Given this list of marker genes CBX7, GSTM5, BUB1B, CKS2, ARL4A, FIBIN, STOML2, NELFB, CACNA2D1, NEK2, TGIF1, SIX4, LBR, PHYH, APOE, ENAH, ALDOA, MIF, DSG2, PTCH1, CACNA1A, CDH3, SNRPA1, ADAM23, PSRC1, DPPA3, FKBP3, FZD5, CPSF4L, SYCP3, SOX2, TUBB4B, TCF7, NADK2, SLC25A40, IFITM3, PMM1, CLDN7, ITM2A, PIM1, KIF20A, SULF2, SLC20A1, CERS4, HNRNPA1L2 (NCBI Gene Id 653821), ASH2L, H2BC4, BCLAF3, G3BP1, PIPOX, IPO5, TUBB2B, MTF2, GRB10, MT1F, CKB, PHB1, DNMT1, CWF19L2, HSP90AA1, HMGA1, MCCC2, TCL1A, IGFBP2, GNG2, FXR1, DPYS, EED, AGR2, AGTRAP, TUBB, TP53INP1, JARID2, MEG3, DUSP6 (NCBI Gene Id 1848), VBP1, EPCAM, HAT1, CTBP2, COL18A1, KLF2, PABIR2, ZFAND6, ALDH7A1, ZMYM1, HMGCS1, SEPTIN1, TFAP2C, GLI1, RIMKLB, S100A6, SPRED1, TUBA1B (tubulin alpha 1b), CARNMT1, SOD2, RFC5, CDCA7L, SPP1, ULK1, TALDO1, NASP, UBXN2B, CYBA (NCBI Gene Id 1535), CDH1, YBX1, COBL, SERBP1, TRH, MDN1, WWC1, PARK7, KIF11, DNAJC21, CUL4B, RUVBL2, MYBL2, ZFP42, DHCR24, RFX2 (NCBI Gene Id 5990), TFRC, ARL6IP1, MANBA, JADE1, TCFL5, TOP2A, SAP30, LAPTM5, XRCC5 (NCBI Gene Id 7520), FAM25A, CRABP1, MT1X, SPINT2, SLC25A13, NUSAP1, LGALS3, KRT19, CCT3, SEPHS2, FDFT1, MAP1B, GNPDA1, SINHCAF, UBE2S, CDKN1C, KCNK1, ST13, CLDN4, EMB, PSMA2, AHSA1, UCHL1, SORL1, OSBPL1A, UHRF1, DBF4, MSH6, CBR3, ENO3, ALDH2, GCLM, ANXA1, RBM3, LDHB, DIAPH1, SYT9, TTC39B, WASF3, LTBP4, SWT1, RESF1, CMAS, FGD1, ACLY, ELAVL2, AMIGO3 (NCBI Gene Id 386724), CPEB1, AURKA, NECTIN3, MIR17HG (NCBI Gene Id 407975), GOLGA4, AKR1B1, IGF2, CUL2, VDAC1, ESCO2, UTF1, CCNE1, PNO1, PRAMEF12, ADH5, CLYBL, PSIP1, ECT2, EBNA1BP2, TPD52, KPNA2, G2E3, STAG3, AKTIP, STRBP, here is a description of the gene set: species: Mus musculus Elongin A is a transcription elongation factor that increases the overall rate of mRNA chain elongation by RNA polymerase II. To investigate the function of Elongin A in vivo, the two alleles of the Elongin A gene have been disrupted by homologous recombination in murine embryonic stem (ES) cells. The Elongin A-deficient ES cells are viable, but show a slow growth phenotype because they undergo a delayed mitosis. The cDNA microarray and RNase protection assay using the wild-type and Elongin A-deficient ES cells indicate that the expression of only a small subset of genes is affected in the mutant cells. Taken together, our results suggest that Elongin A regulates transcription of a subset but not all of genes and reveal a linkage between Elongin A function and cell cycle progression. from publication Yamazaki K, Aso T, Ohnishi Y, Ohno M, Tamura K, Shuin T, Kitajima S, Nakabeppu Y (PMID 12604609) Genes down-regulated in embryonic stem cells from TCEB3 knockout mice. Human Gene Set: YAMAZAKI_TCEB3_TARGETS_DN